Given this list of marker genes DCANP1, NRXN2, DRD2, SLC1A3, CNTNAP2, STRBP, KIAA0319, SLITRK6, NRXN1, SHANK3 (NCBI Gene Id 85358), STRA6, FOXP2, TIFAB, ETV1, NEUROG1, HTT, here is a description of the gene set: Behavior that is dependent upon the sensation of a mechanical stimulus. studied in species Homo sapiens Human Gene Set: GOBP_MECHANOSENSORY_BEHAVIOR